The following is a description of a gene set: studied in species Homo sapiens Mitotic Spindle Checkpoint Human Gene Set: REACTOME_MITOTIC_SPINDLE_CHECKPOINT, and this is the list of marker genes: BUB1B, PPP2CA (NCBI Gene Id 5515), CDC27, CDC20, KNTC1, CENPP (centromere protein P), DYNC1I1, CLASP2, PPP2R5D, MIS12, CKAP5, PPP2R1B, DYNC1I2, CENPF, CENPC, ANAPC2, PPP2R1A, NUDC, B9D2, NUP107, SEH1L, ANAPC7, PAFAH1B1, TAOK1, SGO1, PPP2CB, NUP43, DYNLL2, ANAPC16, CENPA, ANAPC5, BIRC5, INCENP, SKA2, CENPH, SKA1, SPDL1, ZWILCH, CDCA8, CLIP1, ZWINT, KIF18A (NCBI Gene Id 81930), KIF2C, BUB3, DSN1, RPS27, ANAPC15, KIF2B, CENPN (centromere protein N), NSL1, CENPO, UBE2D1, MAPRE1, RANGAP1, MAD1L1, CENPE, NUP133, PPP2R5B (protein phosphatase 2 regulatory subunit B'beta), UBE2C, NDC80, ANAPC1, NUF2, XPO1, ITGB3BP, PPP1CC, NUP85, CENPM, NUP98, NDE1, PLK1, KNL1, PPP2R5E, DYNC1LI2, CENPQ, UBE2S, SEC13, CDC16, DYNC1H1, PPP2R5A, KIF2A, CENPU, CLASP1, NUP160, SPC25 (NCBI Gene Id 57405), SPC24 (SPC24 component of NDC80 kinetochore complex), CENPK, CENPT, AHCTF1, AURKB, DYNLL1, DYNC1LI1, CENPS, PMF1, CDC23, NUP37, ZW10, PPP2R5C, MAD2L1, UBE2E1 (ubiquitin conjugating enzyme E2 E1), BUB1, ERCC6L, CENPI, ANAPC11 (NCBI Gene Id 51529), SGO2, ANAPC4, CDC26, RCC2, RANBP2, CENPL, ANAPC10, NDEL1